The following is a description of a gene set: part of: Reproduction studied in species Homo sapiens Reactome Pathway: Specification of primordial germ cells Primordial germ cells (PGCs), the progenitors of female gametes (oocytes) and male gametes (sperm), are specified and segregated from somatic cells early during mammalian development. In the mouse embryo, precursors of PGCs are present in the proximal epiblast adjacent to the extraembryonic ectoderm before gastrulation (E6.0, pre-streak stage) and PGCs, marked by high alkaline phosphatase activity, are translocated to the extraembryonic mesoderm at the base of the developing allantois during gastrulation. Subsequently, PGCs are regionalised in the epithelium of the embryonic gut and migrate via the dorsal mesentery of the embryonic gut to the genital ridge. The post-migratory PGCs differentiate into oogonia and spermatogonia in the fetal gonad. In mouse embryos, PGCs are induced by Bmp4 emanating from extraembryonic ectoderm and Wnt3 from the visceral endoderm. Less is known about the developmental origin of human PGCs and the sources of inducing signaling factors. In the non human primate (Cynomolgus monkey), PGCs are first observed in the amniotic epithelium of the amniotic sac of the pre-gastrulation embryo and remain in the early amnion for an extended period (6 days). BMP4 is expressed in the amnion and WNT3A is expressed in the cytotrophoblast.<br>Ex vivo and in vitro studies have been performed to elucidate the specification of human PGCs. Putative PGCs, identified by immunofluorescence of PGC markers, are induced in ex vivo culture of early blastocysts (E6 days post fertilization, dpf) and in vitro differentiation of embryonic stem cells (ESCs) or induced pluripotent stem cells (iPSCs) in the presence of BMP4. In both mouse embryos and cultured human cells, competence of the epiblast-like cells to form PGCs in response to BMP4 signals is transient during development, where, in the absence of BMP4, the epiblast-like cells acquire the mesendoderm cell fate.<br>For the induction of PGC-like cells from human pluripotent stem cells, the gene network activity that specifies human PGCs is different from that of mouse PGCs. Notably, SOX17, but not Prdm14, is a key factor for the specification of human PGCs. In human PGC precursors, Eomesodermin (EOMES) activates expression of SOX17, the most upstream factor in PGC specification. Similar molecular events are observed in the early PGCs isolated from human embryos and cynomolgus monkeys. BMP4 signaling initiates the expression of TFAP2C and SOX17, that in turns initiates expression of PRDM1. Together these three key factors, SOX17, TFAP2C, and PRDM1, specify PGCs, activate the PGC program, and repress somatic cell programs, with SOX17 acting as an activator and PRDM1 as a repressor. Genes activated in PGCs include the pluripotency-related factors POU5F1 (OCT4) and NANOG (but not SOX2), the DNA demethylation factor TET2, and the regulators of cell migration PDPN and CXCR4. PRDM1 represses genes involved in DNA methylation leading to a genome wide DNA demethylation in human PGCs around week 10-11 of development. In mouse embryonal carcinoma cells, Prdm1 (Blimp1) binds and represses expression of the de novo DNA methylase Dnmt3b and Uhrf1, which interacts with the DNA methylase Dnmt1. PRDM1 in human PGCs similarly represses expression of DNMT3B, DNMT1, and UHRF1 through yet uncharacterized mechanisms., and this is the list of marker genes: TET2, NANOG, PDPN, CBFA2T2, NANOS3, PRDM1, BMP4, POU5F1, TFAP2C, EOMES, CXCR4, SOX17